Given this list of marker genes RAB11FIP4, CSRNP2, ZBTB10, RNF186, YTHDF2, PRDM2, EIF4EBP2, ALS2, CAMK1D, SOX9, QSER1, MKX, AKAP12, ZBTB33, FAM174B, NAA15 (N-alpha-acetyltransferase 15, NatA auxiliary subunit), SET, CCN1, MED13, NEGR1, ETNK1, MRTFB, MTF1, SMAD5, TENT2, TRIM2, HIC2, KATNBL1, TPR, NUAK1, PCSK5, ABHD17C, DDC, ADI1, ZBTB6, TPM4, KLF5, SLC30A9, MAP4K4, KLHL18, AP2B1, ZMYM5, DYRK1A, SLC25A36 (NCBI Gene Id 55186), UBN2, ACTG1, SRGAP1, UBE2W, BTG1, GLIS1, PRDM1, LAMP2, SEMA3A, TRIO, ITGB8, PLCE1, VWA5A, CRKL, TMEM184A, FKBP3, NTN4, RCBTB1 (NCBI Gene Id 55213), DENND10, PLA2R1 (phospholipase A2 receptor 1), TULP4, AKAP9, RNF207, RASA1, CREB5, RREB1, VPS26A, QKI, BACH2, ANGPT2, CBFB, PHACTR2, SEMA6A, TRPC6, RGS7, CHAC2, TMEM178A, ELK4, ZNF521, OTOR, DLX6, TGFBR2, USP32, PURA, ADAM19, TGFB2, SNTB2, HECTD1, PLCL2, NAA40, DOCK9, MYO6, PALS1, ARF6, LDLRAD3, JPH1, MBTD1, ELMO1, ABCE1, TMEM139, DLC1, REV3L, NAP1L1, COMMD9, CPNE8, HECW2, RAB14, RNF170, GFRA1, ABHD17B, OGT, PSAT1 (phosphoserine aminotransferase 1), SAP30L, CORO2B, PPP3CA, SRGAP2, MYO5A, EBF1, TAGLN2, ABR (ABR activator of RhoGEF and GTPase), SSH2, MYSM1, ABRACL, ITPR2, EBF3, UXS1, DACH1, TPM3, POTEM (NCBI Gene Id 653089), ADAM17, GJA3, HELB, SLC38A11, ERBB4, CAMK2D, FLNB, ARHGAP21, PMP22, FOXO1 (forkhead box O1), GLIS3, SERINC5, ST6GALNAC3, FSCN1, MOSMO, SNX8, UNC119B, HNRNPH2, NET1, EPHA4, SENP2, G3BP1, YES1, CSMD3, NEDD9, RAD51B, EAPP, NRAS, MDFIC (MyoD family inhibitor domain containing), ACTB, CACHD1, BCR, DAW1, USP46, USP31, SLC7A8, GALNT1, MEST, ADAMTS5, USP37, CHP1, SNX27 (sorting nexin 27), CAMKK1, KCNA4, SPATS2, NAA30, ZFYVE9, UBR7, HTR2A, CLCN2, RIMS1, HEY1, ZNF543, KCNK1, RASSF2, BNIP3, AGFG1, RTKN, CCDC148, RIN2, HS6ST1, PDCD4, ATP1A2, ARL6IP5, IPMK, CCDC25, NINL, RANBP2, DAB2, KIF3A (NCBI Gene Id 11127), ANKRD28, RPL36A-HNRNPH2, DENND5B, NDFIP2, C2CD5, PXN, ERG, SOX11, STAM, H2AX, NECTIN3, PLXNA2, AP1G1, INO80, SLC5A6, EPS15, SPSB4, PAN2, TENT4B, IKZF2, TBC1D15, ASAP2, CNTN4, CARMIL1, TMEM9B, OSBPL1A, GABARAPL1, RC3H1, RPS6KB1, TFEC, CITED2, PPP4R2, FLI1, EXOC8, UMODL1, ADD3, ATXN2 (ataxin 2), PSD3, LOX, CASZ1, DNAL1, PRKD3, GABARAPL2, LRRC8B, CACNB2, TMOD2, BLTP3A, MAGI2, CACNA1D, ATP8A1, COL11A1, ARL5B, NDUFA4, COMMD5, KDM7A, ARHGAP6, MYCN, PTPN12, DUSP6, MYRF, TDRD6, RASA2, TAT, KLHL11, CTNND1, ERLIN1, ADCYAP1, LRAT, IFT56, PCBP4, FAM135A, PTGFR, TMEM167A, CLCN3, KCNK9, GRB10, KIF21A, BICC1, IVNS1ABP, ABCA1, NAV3, ZFHX4, TNFRSF11B, VASN, SMAD3, COL6A5, HTATSF1, APLF, NSUN4, EPB41L5, ZBTB20, CAMSAP2, NUFIP2, XRN1, NR4A2 (NCBI Gene Id 4929), GMFB, ZNF626, YTHDC1, FLRT3, MPZL2, ADPGK, UBA6, DLGAP1, here is a description of the gene set: Human Gene Set: MIR145_5P from publication Chen Y, Wang X (PMID 31504780) Genes predicted to be targets of miRBase v22 microRNA hsa-miR-145-5p in miRDB v6.0 with MirTarget v4 prediction scores > 80 (high confidence targets). studied in species Homo sapiens